The following is a description of a gene set: species: Homo sapiens Reactome Pathway: Trafficking of myristoylated proteins to the cilium part of: Cargo trafficking to the periciliary membrane A number of myristoylated proteins have been shown to traffic to the cilium in a myristoyl- and UNC119B:ARL3:RP2-dependent fashion. These include the ciliary proteins Nephrocystin 3 (NPHP3) and Cystin 1 (CYS1). Myristoyl-binding by the ARL3 effector UNC119B is required in an unknown fashion for the transport of the myristoylated cargo to the cilium. At the cilium, a GTPase cycle involving the ARF-like small GTPase ARL3 and its GAP protein RP2 promote the release of the myristoylated proteins into the ciliary membrane and the recycling and ciliary exit of UNC119B. ARL3 plays additional roles in the cilium coordinating the association of IFT A and IFT B complexes with the kinesin motors., and this is the list of marker genes: ARL3, UNC119B, CYS1, NPHP3, RP2